Given this list of marker genes INTS2, JAG1, KMT5A, G3BP2, RBFOX2, MBNL1, TPR, TRAPPC8, CTSB, GABRA4, BTBD3, CSNK2A1, GABPB2, SLC25A3, WNK3, OSGIN2, COP1, OTUD4, PLS3, UBE2B, DPH2, PID1, PDCD10, PPM1B, TARDBP, ZHX1, DLG5, EFEMP1, SALL1, PCDHA10, PARG, HOXA9, SEPTIN7, GNAZ, UPF1, SOX11, SUCLA2, MCFD2, CAST, ABRAXAS1, PHF21B, NXPH1 (neurexophilin 1), MAP4, SUMO1, NR4A2, COL3A1, PPP1CC, FNDC3B, PSPH, SP4, PPP1CB, MORC2, VEGFA, PRDM1, CD200R1, PLPPR4, PCDHA9, PPM1G, MAPK1, DPP9, TRPC1, VCF1, ICMT (NCBI Gene Id 57087), TMED7, LRBA, BCL11B, TOB1, HNMT, KCND2, EED, MAPKAP1, CSDE1, APLP2, BTF3, ACSL4 (NCBI Gene Id 4426, acyl-CoA synthetase long chain family member 4), FAM217B, PLP1 (proteolipid protein 1), FAR1, FNDC3A, SRPK1, MOSPD1, ZNF385A, EIF4E, CADM2, ZFHX4, SCAF8, ZC3H18, NCOA2, DLC1, ARGLU1, PCDHA5, PCDHA1, RBFOX1, OSBPL8, TMEM35A, DNM3, EIF4E3, FBXO33, MTPN, CACNB3, EP300, HNRNPU, PCDHAC2, TBL1XR1, TSC22D2 (NCBI Gene Id 9819), SPAST, NASP, SYAP1, GARRE1, GPR85, NECAB1, MOSMO (modulator of smoothened), RNF11, BAZ2B, SMPD3, DDX3X, EXT2, FOXD1, JPH1, XIAP, SNX27, WIPF1, RPS6KA3, PCDHA12, CPEB3 (cytoplasmic polyadenylation element binding protein 3), CNTNAP1, JPH3, PCDHA4, NME7, SPSB1, TRPS1, DOK6, EIF2S2, CDC5L, TMEM182, PAPPA, MAP3K2, SLC23A2, STAG2, RB1CC1, NR3C2, C5orf24, PCDHA6, PCDHA2, PCDHA3, KCNMA1, MAP2, YY1, OXSR1, LRRN1, PAK5, MYT1 (myelin transcription factor 1), BRINP2, QKI, AHCYL1, FAM193B (NCBI Gene Id 654030), PXDC1, PCDHA13, CCNT2, HOOK3, BACH2, CLDN1, PDS5B, TRIM67, IGF2BP2, IL2, PCDHA7, CAPZA1, BCAR3, CPEB4, SENP6, RASA3, WNT5A, BUB3, RABIF, ZBTB39, OTX1, CDC42, CABS1, ZCCHC14, LMBR1, AMOT, TENT4A (NCBI Gene Id 11044), DDX3Y, TUT4, LIN28A, MYT1L, GRIN3A (NCBI Gene Id 138370), PRDM10, ZMYM2, CNTNAP2, SEC62, S1PR3, HYOU1, PDGFC, ELAPOR2, NFAT5, ZNF20, CRAMP1, NUS1, RPS6KB1, BCL9, ENC1, CALB1, NR5A2, PURB, HOXB8, GTDC1, TGFBR2, EPHB1, FRMD4A, ZZZ3, RGS5, CLK4, RAB6A, CXCL13, P2RX7, ZFAND3 (NCBI Gene Id 60685), SH3RF1, SNAP91 (synaptosome associated protein 91), UBQLN2, ZC3H11A, FICD, LRCH2, RAB21, ZFP36L1, PFKFB4, PABPC1, RBM26, ZBTB41, RIOK3, CPEB2, CXXC5, SRPK2, PCDHA11, UBE3A, ITGA6, INSM1, PAN3, WDFY3, PCDHA8, ADGRL2, SAT1, EPN2, PNN, NAA15, PSME3, PTGES3, MBNL2, PCDHAC1, SMAD6 (NCBI Gene Id 4091), SGPP1, SP3, CEP192, ZNF608, EPC2, MRPL3, PSMD11, EIF3A, PDS5A, MITF, TMED2, IGSF11, CELF1, CRK, TCF20, MIER1, MEX3B, NEGR1, PRPF39, PABPC3, here is a description of the gene set: species: Homo sapiens Human Gene Set: ATTCTTT_MIR186 Genes having at least one occurence of the motif ATTCTTT in their 3' untranslated region. The motif represents putative target (that is, seed match) of human mature miRNA hsa-miR-186 (v7.1 miRBase).